The following is a description of a gene set: Genes predicted to be targets of miRBase v22 microRNA mmu_miR_6921_5p in miRDB v6.0 with MirTarget v4 prediction scores > 80 (high confidence targets). Mouse Gene Set: MIR_6921_5P from publication Chen Y, Wang X (PMID 31504780) studied in species Mus musculus, and this is the list of marker genes: Numbl, Syp, Arhgef4, Opa3, Krt88, Celsr2, Dlgap3 (NCBI Gene Id 277683), Hbp1, Nav1, Trappc14, Cd177, Erf, Zfp609, Lasp1, Rab11b, Adar, Zmym4, Clec16a, Ttll4, Selp (NCBI Gene Id 20344), Cp, Chga, Pip5k1c, Odc1, Kcnq2, Clcn4, Glis2, Slc20a2, Rell2, Thy1, Srl, Map1lc3a, Atp8b2, Gjb1, Upk3b, Pak3, Dlk1, Akap13, Sdc2, Golph3, Ark2c, St6galnac6, Ucn3, Csf1, Dscam, Chd3, Grhl2, Zwint, Enc1, Laptm5, Cers2 (NCBI Gene Id 99568), Cdh13, Snph, Foxp4, Agap3, Gpatch8, Nudt3, Eng, Bap1, Gns, Yars2, Lypd10, Rgma, Rab40c, Srsf1, Fam3a, Acsf2, Arid3b, Rnf214, Baz2a, Samd4b, Sox12 (NCBI Gene Id 69985), Fndc11, Clk2, Mien1, Cxcl14, Tfdp1, Ganab, Tmem150a, Cops4, Acap3, Nrsn2, Gpr161, Sez6, Hddc3, Mtcl2, Lypd11, Eri3, Cables2, Zbtb24, Pianp, Shank1, Mras, Mavs, Septin9, Faf2, Fam222b, Ypel1 (NCBI Gene Id 93818), Abcc5, Cyp4f39, Spryd3, Myh14, Micall1, Smarcc2, Zdhhc9